The following is a description of a gene set: Detoxification of Reactive Oxygen Species Mouse Gene Set: REACTOME_DETOXIFICATION_OF_REACTIVE_OXYGEN_SPECIES studied in species Mus musculus, and this is the list of marker genes: Txnrd2, Nudt2, Ncf4, Txn1 (NCBI Gene Id 22166), Ncf2, Prdx6, Prdx3, Gsr, Prdx1, Sod2, Sod1 (NCBI Gene Id 319325), Gpx6, Cycs, Ero1a, Gstp2, Gpx8, Gm10053, Cyba, Gpx1, Gstp1, Gpx7, Txnrd1, Prdx5, Sod3, Ccs, Nox4, Gpx3, Cybb (cytochrome b-245, beta polypeptide), Gpx2, Gpx5, P4hb, Txn2, Cat, Prdx2, Ncf1